The following is a description of a gene set: studied in species Homo sapiens Human Gene Set: GOBP_PURINE_NUCLEOSIDE_TRIPHOSPHATE_CATABOLIC_PROCESS The chemical reactions and pathways resulting in the breakdown of purine nucleoside triphosphate, a compound consisting of a purine base linked to a ribose or deoxyribose sugar esterified with triphosphate on the sugar., and this is the list of marker genes: ITPA, NUDT15, NUDT16, SAMHD1, ADA